Given this list of marker genes DRD2, ABCG2, NPPB, UMOD, STC1, CLN3, MLLT6, AGT, EDN1, NHERF1, NPR1, SPX, ATP6V1B1, CORIN, ATP6V0A4, AGTR1, EDNRB, COMT, SLC22A12, SLC22A6 (solute carrier family 22 member 6), here is a description of the gene set: The elimination of substances from peritubular capillaries (or surrounding hemolymph in invertebrates) into the renal tubules to be incorporated subsequently into the urine. Substances that are secreted include organic anions, ammonia, potassium and drugs. species: Homo sapiens Human Gene Set: GOBP_RENAL_TUBULAR_SECRETION